Given this list of marker genes PIK3R4, BECN2, ATG14, NRBF2, UVRAG, PIK3C3, BECN1, here is a description of the gene set: studied in species Homo sapiens A phosphatidylinositol 3-kinase complex that contains a catalytic class III phosphoinositide 3-kinase (PI3K) subunit bound to a regulatory (adaptor) subunit. Additional adaptor proteins may be present. Class III PI3Ks have a substrate specificity restricted to phosphatidylinositol (PI). Human Gene Set: GOCC_PHOSPHATIDYLINOSITOL_3_KINASE_COMPLEX_CLASS_III